Given this list of marker genes Crh, Htr1a, Cd300a, Hrh3, Cnr1 (NCBI Gene Id 12801), Htr1b, Crhr2, Slc6a4, Maob, Htr7, Lgals3, here is a description of the gene set: Any process that modulates the frequency, rate or extent of the regulated release of serotonin. Mouse Gene Set: GOBP_REGULATION_OF_SEROTONIN_SECRETION species: Mus musculus